Given this list of marker genes RPL10, GMPPB, NDE1, FOCAD, LTBP1, ELN, PKP2, FBLN5, ALDH18A1, NPPA, EFEMP2, here is a description of the gene set: A localized outpouching of ventricular cavity that is generally associated with dyskinesia and paradoxical expansion during systole. Human Gene Set: HP_DILATATION_OF_THE_VENTRICULAR_CAVITY Dilatation of the ventricular cavity species: Homo sapiens